The following is a description of a gene set: Human Gene Set: GOBP_NEGATIVE_REGULATION_OF_CHOLESTEROL_BIOSYNTHETIC_PROCESS Any process that stops, prevents, or reduces the frequency, rate or extent of the chemical reactions and pathways resulting in the formation of cholesterol. studied in species Homo sapiens, and this is the list of marker genes: APOE, MIR342, SCAP, ERLIN2, ERLIN1, MIR185 (microRNA 185), MIR548P, MIR98, MIR30C1, C7orf50, INSIG1